The following is a description of a gene set: species: Homo sapiens Reactome Pathway: tRNA Aminoacylation part of: Translation tRNA synthetases catalyze the ligation of tRNAs to their cognate amino acids in an ATP-dependent manner. The reaction proceeds in two steps. First, amino acid and ATP form an aminoacyl adenylate molecule, releasing pyrophosphate. The aminoacyl adenylate remains associated with the synthetase enzyme where, in the second step it reacts with tRNA to form aminoacyl tRNA and AMP. The rapid hydrolysis of pyrophosphate makes these reactions essentially irreversible under physiological conditions. Specificity of the tRNA charging reactions is achieved both by specific recognition of amino acid and tRNA substrates by the synthetase, and by an editing process in which incorrect aminoacyl adenylate molecules (e.g., valyl adenylate associated with isoleucyl tRNA synthetase) are hydrolyzed rather than conjugated to tRNAs in the second step of the reaction. The tRNA synthetases can be divided into two structural classes based on conserved amino acid sequence features.<p>A single synthetase mediates the charging of all of the tRNA species specific for any one amino acid but, with three exceptions, glycine, lysine, and glutamine, the synthetase that catalyzes aminoacylation of mitochondrial tRNAs is encoded by a different gene than the one that acts on mitochondrial tRNAs. Both mitochondrial and cytosolic tRNA synthetase enzymes are encoded by genes in the nuclear genome.<p>A number of tRNA synthetases are known to have functions distinct from tRNA charging. Additionally, mutations in several of the tRNA synthetases, often affecting protein domains that are dispensable in vitro for aminoacyl tRNA synthesis, are associated with a diverse array of neurological and other diseases. These findings raise interest into the role of these enzymes in human development and disease.<p>, and this is the list of marker genes: TARS2, NARS2, IARS1, YARS1, NARS1 (NCBI Gene Id 9243), PPA2, FARS2, IARS2, RARS2, LARS1, SARS2, AIMP2, WARS2, FARSB, DARS2 (NCBI Gene Id 55157), LARS2, PPA1 (NCBI Gene Id 5464), WARS1, YARS2, EARS2, TARS1, AIMP1, MARS2, VARS1, FARSA (phenylalanyl-tRNA synthetase subunit alpha), EEF1E1, DARS1, GARS1, AARS1 (alanyl-tRNA synthetase 1), HARS2 (histidyl-tRNA synthetase 2, mitochondrial), EPRS1, CARS2, AARS2, PARS2, KARS1, MARS1, QARS1, VARS2, SARS1, HARS1, CARS1, RARS1